The following is a description of a gene set: Reversible hydration of carbon dioxide studied in species Mus musculus Mouse Gene Set: REACTOME_REVERSIBLE_HYDRATION_OF_CARBON_DIOXIDE, and this is the list of marker genes: Car12, Car13, Car14, Car9, Car3, Car6, Car7, Car1, Car2, Car5a, Car5b, Car4 (NCBI Gene Id 12351)